Given this list of marker genes PRMT7, PRMT5, PRMT1, PRMT8, NDUFAF7, here is a description of the gene set: Human Gene Set: GOBP_PEPTIDYL_ARGININE_METHYLATION The addition of a methyl group to an arginine residue in a protein. species: Homo sapiens